The following is a description of a gene set: from publication Motenko H, Neuhauser SB, O'Keefe M, Richardson JE (PMID 26092688) Mouse genes annotated to increased mammary gland tumor incidence (MP:0010299) retrieved from the Mouse Genome Informatics database via MouseMine studied in species Mus musculus Mouse Gene Set: MP_INCREASED_MAMMARY_GLAND_TUMOR_INCIDENCE, and this is the list of marker genes: Cdkn2c, Cyp19a1, Becn1, Stk3, Fbxo4, Trp53, Sirt2, Brca2, Rev3l, Msh2, Met, Erbb2, Men1, Rint1, Pinx1 (PIN2/TERF1 interacting, telomerase inhibitor 1), Mcm4, Blm, Pten, Helq, Fzr1, Tom1l2 (target of myb1-like 2 (chicken)), Apc, Brca1, Cav1, Pik3ca, Ets2, Bin1, Myc, Lzts1 (NCBI Gene Id 665540), Wnt1